The following is a description of a gene set: species: Homo sapiens Human Gene Set: GOCC_SM_LIKE_PROTEIN_FAMILY_COMPLEX A protein complex containing members of the Like-Sm family of proteins, which includes both the Sm proteins and the Lsm proteins, and which generally form hexameric or heptameric ring structures which bind to RNA. While some of these ring complexes may form independently of RNA, many only form in association with their target RNA. In addition to Lsm-family proteins, many of these complexes contain additional protein members. Members of this family of complexes include the snRNPs which comprise the majority of the spliceosome. Others are involved in the 5' to 3' degradation pathways of mRNAs in the cytoplasm and of unspliced transcripts in the nucleus, as well as other diverse roles., and this is the list of marker genes: RNU6ATAC, SNRNP70, SNRPE, SNRPB, GEMIN4, TXNL4A, LSM11, USP39, RNVU1-7, LUC7L3, SF3A1, SNRPD2, LSM4, SNRPB2, SNRPA1, RNU4-1, STRAP, LSM5, LUC7L2, RNU2-1, SF3B1, SART1, PRPF40A, RNVU1-14, RBM42, DDX39B, SMN1, GEMIN2 (NCBI Gene Id 8487), SF3B3, SMN2, MEPCE, PRPF31, RNU5A-1, TGS1, GEMIN5, RNVU1-6, RBMX2, SNRPA, U2SURP, RNU6-7, PRPF8, SF3B2, DDX20, TXNL4B, RNVU1-1, RNU4ATAC, PRPF6, RNU6-9, SF3A3, BUD13, PRPF40B, SNRPG, DDX23, RNU11, PRPF39 (pre-mRNA processing factor 39), GEMIN6, PPIH, RNVU1-3, SNRPC, SNRNP40, LSM10, HEXIM1, DDX46, RNU5D-1, PRPF18, SF3B4, ZMAT2, SLU7, SF3B6, RNU1-4, RN7SK, SF3B5, RNU5E-1, RNU5B-1, LSM8, RNVU1-2A, SNIP1, RNVU1-4, CD2BP2, HTATSF1, WEE2-AS1, SNRPD3, RNU5F-1, PHF5A, TAF12-DT, RNU4-2, EFTUD2, GEMIN8, ARFGEF1, SNRNP27, AAR2, CLNS1A, SNRPGP15, LSM7, TSSC4, RNVU1-15, SNRPN, RNVU1-8, LARP7, RNU6-1, LSM1, LSM2, FMR1, SNRNP200, LSM3, SNU13, RNVU1-19 (RNA, variant U1 small nuclear 19), PRPF4, SART3, SF3A2, SNRPF, LUC7L, PRPF3, GEMIN7, LSM6 (NCBI Gene Id 730962), RNVU1-17, SNRPD1